The following is a description of a gene set: The orderly movement of a cell from one site to another that will contribute to the progression of the metanephric kidney over time, from its formation to the mature organ. Mouse Gene Set: GOBP_CELL_MIGRATION_INVOLVED_IN_METANEPHROS_DEVELOPMENT studied in species Mus musculus, and this is the list of marker genes: Pdgfrb, Pdgfa, Pdgfb, Gdf6, Adipoq